Given this list of marker genes Wnt5a (NCBI Gene Id 77565), Eif2ak3, Bmp2, Sox3, Nr0b1, Cyp1b1, Ednra, Sidt2, Mnx1, Pax1, Clock, Insm1, Nkx6-1, Bad, Mir7-1, Hes1, Apoa1 (NCBI Gene Id 11806), Nkx2-1, Bmal1, Gipr, Tubb1 (NCBI Gene Id 72817), Clu, Prop1, Gsx1, Men1, Cited2, Hoxb3, Tgfbr1, Sox2, Rheb (Ras homolog enriched in brain), Pbx1, Mir375, Crhr1, Pdpk1, Gata6, Mir541, Hoxd3, Crh, Pax6, Gli2, Gip, Reg1, Smad4, Wnt4, Aldh1a2, Gcm2, Slc6a3, Nr3c1, Crkl, Mir214, Ascl1, Bmp4, Hmga1, Otp, Nkx2-2, Pitx1 (NCBI Gene Id 18740), Gli1, Gata2, Cdh2 (NCBI Gene Id 12558), Foxe1, Tspo, Il6, Rfx3, Dkk3, Nog, Hesx1 (homeobox gene expressed in ES cells), Pou1f1, Lhx3, Bmpr1a, Mapk3, Nkx6-2, Smo, Cga, Drd2, Bmp6, Bhlha15, Armc5, Pdgfra, Ghrh, Myt1, Fgf8, Insr, Vhl, Ly6e, Pou3f2, Kdm1a, Wnt11, Cftr, Adcyap1, Dll1, Isl1, Arid5b, Ghrhr, Onecut1, Rap1gap, Wt1, Hhex, Rfx6, Bmp5, Duox2, Inhbb, Map2k2, Six1, Raf1, Cdkn1c, Ier3ip1, Pdgfrb, Six3, Gdf11, Smad2, Igf1r (NCBI Gene Id 77773), Pitx2, Pcsk1, Neurod1, Sox9, Pdx1, Tg, Hnf1b, Smad3, Thra (NCBI Gene Id 319227), Fgf10, Nr5a1, Pax4, Foxi3, Edn1, Mdk, Nf1, Fgf2, Tcf7l2, Rbpj, Bak1, Pde3b, Srf, Tbx1, Il6ra, Hoxa5, Ctns, Zfp800, Hoxa3, Mir503, Hmga2, Mapk1, Creb1, Sox4, Onecut2, Nkx2-5, Cdk6 (NCBI Gene Id 330039), Stra6, Braf, Map2k1, Tbx19, Pax8, Gata3, Hipk2, Shh, Foxa2, here is a description of the gene set: Progression of the endocrine system over time, from its formation to a mature structure. The endocrine system is a system of hormones and ductless glands, where the glands release hormones directly into the blood, lymph or other intercellular fluid, and the hormones circulate within the body to affect distant organs. The major glands that make up the human endocrine system are the hypothalamus, pituitary, thyroid, parathryoids, adrenals, pineal body, and the reproductive glands which include the ovaries and testes. species: Mus musculus Mouse Gene Set: GOBP_ENDOCRINE_SYSTEM_DEVELOPMENT